The following is a description of a gene set: Cargo recognition for clathrin-mediated endocytosis species: Homo sapiens Human Gene Set: REACTOME_CARGO_RECOGNITION_FOR_CLATHRIN_MEDIATED_ENDOCYTOSIS, and this is the list of marker genes: LRP2, STAM, KIAA0319, EPS15L1, NECAP2, EPS15 (NCBI Gene Id 2060), TF, AP2A2, GRB2, CD3D, CD4, FCHO2, WNT5A, UBB, DVL2, RPS27A, SH3GL1, AVPR2, VAMP4, IGF2R, SYT9, COPS3, SNAP91, TGFA, CLTC, AGFG1, SCARB2, AGTR1, TFRC, SYT11, COPS5, PICALM, AREG, AAK1, REPS1, HGS, ARRB2, M6PR, UBC, SH3KBP1, COPS7B, COPS8, LDLR, UBQLN1, COPS4, VAMP2, NECAP1, VAMP8, NEDD8, SLC2A8, VAMP3, CBL, SYT1, STON2, CHRM2, CD3G, LDLRAP1, CLTB, APOB, EPGN, SYT2, ITSN1, EPN2, BTC, AP2A1, TOR1A, GRK2, FCHO1, UBQLN2, SGIP1, SH3GL2, TOR1B, EGF, AP2B1, STON1, ITSN2, AP2M1, CLTA, REPS2, DAB2, COPS2, HBEGF (heparin binding EGF like growth factor), STAM2, SH3GL3, EPN1, GPS1, FZD4, IL7R, EGFR, TACR1, TGOLN2, SYT8 (NCBI Gene Id 90019), ARRB1, AP2S1, CLTCL1, AVP, COPS6, CFTR (CF transmembrane conductance regulator), SLC18A3, GRK3, UBA52, COPS7A, ADRB2, VAMP7, EREG